The following is a description of a gene set: Human Gene Set: GSE27786_CD8_TCELL_VS_NEUTROPHIL_DN from publication Konuma T, Nakamura S, Miyagi S, Negishi M, Chiba T, Oguro H, Yuan J, Mochizuki-Kashio M, Ichikawa H, Miyoshi H, Vidal M, Iwama A (PMID 21540074) studied in species Homo sapiens Genes down-regulated in comparison of CD8 T cells versus neutrophils. Each fraction of mouse hematopoietic cells was purified by cell sorting from bone marrow of 8-week-old C57BL/6 mice, and its gene expression was analyzed., and this is the list of marker genes: PRKAB1, NIN, AFDN, EGFL6, CHRNA1, PEF1, NRG2, RHBDF1, RGS6, FOXN2, MLKL, THAP1, TMEM165, POMT2, ARID3B, TMEM30A, CCHCR1, RAPGEF2 (NCBI Gene Id 9693), RAD51AP1, ACKR2, HMGB2, GJA4, FBXL19, SASS6, LYPD4, MFSD4B, CCNA2, PTPN9 (protein tyrosine phosphatase non-receptor type 9), LYRM2, ACTG2, CDC27, OSBPL7, HPCAL1, BRD9, CA10, PBK, SEPTIN9 (septin 9), RMND5B, MYO19, BABAM2, SEM1, DMBX1, IRS2, TBC1D14, GAS2L3, TMPRSS6, SLAMF9 (NCBI Gene Id 89886), RGN, AQP9, HEXB, NRP1 (NCBI Gene Id 8829), DDX60, ARHGAP23, TRAFD1, NFU1 (NCBI Gene Id 80767, NFU1 iron-sulfur cluster scaffold), MLX, CRYZL1, ENO1, MMRN2, PPP1R18, LSP1, PHF10, ARHGAP30, ZNF217, PALM, SIK2, MPP1, DOK7, ING4, TRAPPC10, TIAM2, CPEB2, RBM38, MIEF2, CCDC126, ATXN1L (ataxin 1 like), MINDY1, ZYX, PRSS23, ZNF652, HNRNPLL, HEATR6, SLK, GPR153, SLC2A6, ATP11C (NCBI Gene Id 57206), ARRDC4, DHRS3, TMEM81, CDK14, SLC7A11, ANKRD46, E2F8, DNMT3L, DEPTOR (DEP domain containing MTOR interacting protein), HIPK2, GORASP1 (NCBI Gene Id 64689), CACNA1E, SEPHS2, IL1RAP, CA9, KNDC1, GLB1L2, CFAP119, CHKB, UXS1 (NCBI Gene Id 80146), GPC1, NISCH, DNAAF9, H2AX, UFD1, TRPM2 (transient receptor potential cation channel subfamily M member 2), RANBP9, RHBDL2, SIX6, STEAP2, HTRA2, PAG1, PKD2, RSPH3, TRAM2, CDCA8, NFIC (NCBI Gene Id 4782), MS4A15, ENPP2, CENPE, CD4, PIGU, SGK3, ACAP1, CDK2AP2, LRR1, GLIPR1, HOXA1, PDIA2, HSPA13, PIK3AP1, NNT, TPI1, AKT2, GTPBP2, NFKBIL1, BTD, NKIRAS2, ARAP1, ABCD1, EPM2A, NAA35, FUT2, MAPKAPK5, IREB2, MASTL, HPN, KLHL12, TMEM63A, RGP1 (RGP1 homolog, RAB6A GEF complex partner 1), PPP2CB, TMEM167B, HSD17B14, TSC2, MDM2, ZXDC, TKFC, BATF2, C22orf23, CTNNA1, ASB6, ACTN4, LRRTM1, ACVR1B, SOS2, ACAP3, SCAPER, ZMYND11, RIOX1, CEP128, RALGAPA1, FAM221B, SELENOT, TRAPPC5, TMEM120A, FUT7, TEAD1, SLC17A7, RGMB, SH2D4A, ARHGEF4, CBLIF, LRRC4B, INCENP, USP49, PNPLA7, GINM1, MYO3A, UBD, PDLIM2, IQSEC1, SSC4D, KIF5B